The following is a description of a gene set: Genes down-regulated in normal hematopoietic progenitors by RUNX1-RUNX1T1 fusion. The t(8;21)(q22;q22) occurs frequently in acute myelogenous leukaemia and gives rise to the transcription factor fusion protein, RUNX1-RUNX1T1 (also known as AML1-ETO). To identify the genes dysregulated by the aberrant transcriptional activity of RUNX1-RUNX1T1, we used microarrays to determine the effect of this mutation on gene expression in human progenitor cells and during subsequent development. Gene signatures of these developmental subsets were very dissimilar indicating that effects of RUNX1-RUNX1T1 are highly context dependent. We focused on gene changes associated with the granulocytic lineage and identified a clinically relevant subset of these by comparison with 235 leukaemia patient transcriptional signatures. We confirmed the overexpression of a number of significant genes (Sox4, IL-17BR, CD200 and gamma-catenin). Further, we show that overexpression of CD200 and gamma-catenin is also associated with the inv(16) abnormality which like RUNX1-RUNX1T1 disrupts core binding factor activity. We investigated the functional significance of CD200 and gamma-catenin overexpression in normal human progenitor cells. The effect of IL17 on growth was also assessed. Individually, none of these changes were sufficient to recapitulate the effects of RUNX1-RUNX1T1 on normal development. These data provide the most comprehensive and pertinent assessment of the effect of RUNX1-RUNX1T1 on gene expression and demonstrate the highly context-dependent effects of this fusion gene. studied in species Homo sapiens Human Gene Set: TONKS_TARGETS_OF_RUNX1_RUNX1T1_FUSION_HSC_DN from publication Tonks A, Pearn L, Musson M, Gilkes A, Mills KI, Burnett AK, Darley RL (PMID 17898786), and this is the list of marker genes: SLC1A4 (NCBI Gene Id 6509), RAMP1, TGFBI, MS4A3, TRBC2, CEBPA, TMEM156, DOK2, NOD2, NCF4, CXCR4, IGFBP5, GMPR, CD55, OGG1, FHL2, STK10, EGR3, FPR2, CCND1, GSR, IL7, IRF8, C11orf21, SLC48A1, IGFBP2, FADS1, PRG2, MGAT1, ANPEP, TSC22D1 (NCBI Gene Id 8848), ZBTB16, MBP, ZFP36L2, CD33, CIAO1, LAT2, ACTN1, PLPP1, FCER1A, HBA1, SLC7A5 (solute carrier family 7 member 5), CST7, SLCO3A1 (solute carrier organic anion transporter family member 3A1), CHST12, ADCY7, LDLRAP1, RMND5B, PIK3CB, STAB1, DMTN, GATA1, MMP2, GALNT6, ADGRE2, HBG1, ANK1, CCND3, CCR7, SLC16A3, TIMP3, ACSL1, PTPN22, TEAD3, APOBR, CBFA2T3, SETX, SMOX, CCL2 (NCBI Gene Id 6347), GPR183, ID2, GFI1B, SLA, ELOVL6, TNFSF13, TYROBP, CCNA1, CD244, IL1RN, RNF125, CRCP, LDLRAD4, HBBP1, C15orf39, PLXNC1, PLCH1, TRGC1, ABCC4, PDLIM1, GPR35, GATA2, ITGAL, NFE2, SOCS1, TUBB4BP7, RGS14, TRAF4, CD48, ZNF787, CSTA, AQP3, CD36, PTPN12, SLC43A3 (solute carrier family 43 member 3), EHD3, CYBB, RUNX3, BIN2, LCP2, S100A4, BCOR, RPS6KA1, DUSP10, SASH3, ARHGEF10, CAMK1, KBTBD11, CAPG (capping actin protein, gelsolin like), NKG7, BIRC3, CYP51A1, LAT, CTSG, JUND, SPI1, CD82, TESC, SLCO4C1, LTB, KCNH2, FUT7, IL6R, SLC27A2, CFLAR, RASSF2, E2F8, P2RX5, CD52, RPS4XP9, PLP2, SLC16A7, RBM38, IL7R, MAGEF1, CLC, HDC, S100B, MICAL2, XK, TUBA4A, HBB, LST1, CEBPE, FAM30A, CSF1, PDXK, MYCN, PLAC8, FADS2, KLF1, IL17RA, NEFH, PRKCD, FCGR2A, TPCN1, PMP22, TPM1, CSF2RB, ALOX5AP, LGALS1, SH3BGRL3, EXOSC4, IL10RA, ITGA6, GSE1, KCNK5, IGFBP4, RARA, DYRK2, ASRGL1, RHOH, MYL4, LAPTM5, CYP1B1, FLOT2, CKAP4, ITGA2B, HBD, TFR2, XYLT1, IL9R, SELPLG, S100A9